The following is a description of a gene set: from publication Riz I, Akimov SS, Eaker SS, Baxter KK, Lee HJ, Mariño-Ramírez L, Landsman D, Hawley TS, Hawley RG (PMID 17213805) Human Gene Set: RIZ_ERYTHROID_DIFFERENTIATION Aberrant expression of the human homeobox-containing proto-oncogene TLX1/HOX11 inhibits hematopoietic differentiation programs in a number of murine model systems. Here, we report the establishment of a murine erythroid progenitor cell line, iEBHX1S-4, developmentally arrested by regulatable TLX1 expression. Extinction of TLX1 expression released the iEBHX1S-4 differentiation block, allowing erythropoietin-dependent acquisition of erythroid markers and hemoglobin synthesis. Coordinated activation of erythroid transcriptional networks integrated by the acetyltransferase co-activator CREB-binding protein (CBP) was suggested by bioinformatic analysis of the upstream regulatory regions of several conditionally induced iEBHX1S-4 gene sets. In accord with this notion, CBP-associated acetylation of GATA-1, an essential regulator of erythroid differentiation, increased concomitantly with TLX1 downregulation. Coimmunoprecipitation experiments and glutathione-S-transferase pull-down assays revealed that TLX1 directly binds to CBP, and confocal laser microscopy demonstrated that the two proteins partially colocalize at intranuclear sites in iEBHX1S-4 cells. Notably, the distribution of CBP in conditionally blocked iEBHX1S-4 cells partially overlapped with chromatin marked by a repressive histone methylation pattern, and downregulation of TLX1 coincided with exit of CBP from these heterochromatic regions. Thus, we propose that TLX1-mediated differentiation arrest may be achieved in part through a mechanism that involves redirection of CBP and/or its sequestration in repressive chromatin domains. studied in species Mus musculus Selected gradually up-regulated genes in the TLX1 Tet On iEBHX15-4 cells (pro-erythroblasts)., and this is the list of marker genes: CBX3 (NCBI Gene Id 82756), CLOCK, FOXH1, NFYC, ZBTB17, PIAS3, PIAS2, MYBL2, TOP2A, MCM2, POU2F3, BMAL1, UHRF1, POLG2, ANKFY1, SP3, DNMT1 (DNA methyltransferase 1), STAT5B, HNRNPDL, NFYB, CENPB, CENPC, PER3, RAB7A, BRCA1, DHX9, NFIX, MCM7, MAX, FOSL2, STAT1, TFDP1, ID1, POLE2, SUPT4H1, CDKN2D, KIF4A, TRIM27, HSF1, MAFG, POLA1, ANKRD49, RXRA, ATF1, BMI1, HMGB1, FEN1, CTCF, ETAA1, HMGN2, RBL1, YBX3, TERF2, PBX2, GCM2, MID1, HMGB2, MCM4, GATA1, SMAD6, C1D, PAX4, POLD1, CCNC, ANK1, MBD4, E2F1, AURKB, MCM5, CENPA, RAB2A, SMARCE1, EZH2, H3C1, POU2F1, PLA2G6 (NCBI Gene Id 8398), ELF4, POLR2J, EXO1, MCM3, RAB1A, BLM